The following is a description of a gene set: Human Gene Set: GSE8515_CTRL_VS_IL6_4H_STIM_MAC_DN from publication Jura J, Wegrzyn P, Korostyński M, Guzik K, Oczko-Wojciechowska M, Jarzab M, Kowalska M, Piechota M, Przewłocki R, Koj A (PMID 18498781) Using whole-genome Affymetrix microarrays (HG-U133A), we characterized the transcriptome profile of cultured human macrophages stimulated for 4 h with interleukin 1 (IL-1) or interleukin 6 (IL-6). We found that, in distinction to liver cells, IL-1 is much more potent than IL-6 in modifying macrophage gene expression, although considerable heterogeneity in response of macrophages deriving from individual blood donors was observed. The obtained results permitted to identify a large number of cytokine-responsive genes. coding for proteins of unknown function that are now being studied in our laboratory. They may represent novel targets in the anti-inflammatory therapy. studied in species Homo sapiens Genes down-regulated in comparison of untreated macrophages versus those treated with IL6., and this is the list of marker genes: NTHL1, STK32B, PAX5, IGFALS, EEF2KMT, OPRK1, CCDC134, SBF1, AAMP, ITGB1BP2, MRPS18B, ZNF480, ZFR2, TUBA1C, BRCA1, PLPPR2, PROP1, MAL, CNKSR1, EGLN2, SAMD14 (NCBI Gene Id 201191), IGFBP2, MMS19, POLH, SCNN1A, MCM3AP, FZD8, NRXN2, AKAP6, AASS, BAHCC1, SYMPK, AZGP1, AGPAT4, FAM153A, CORO7, MORC4, SLC6A15, ATXN2L, KCNC1, DNAJA3, C14orf93, GLI1 (NCBI Gene Id 2735), NPC1, ARMCX4, ENTPD2, IHH, RIMS1, CPLX2, LDB2, EDN3, C10orf95-AS1, RBFA, DMTN, WNT4, USH2A, RTL10, NHLH1, UPK3B, LORICRIN, NPTXR, CDH19 (NCBI Gene Id 28513), HS3ST1, SCN2B, IL4R, CA8, OR1E1, ITGB6 (NCBI Gene Id 3694), UTY, POSTN, PTK2, ABCB11, ST3GAL4, LIM2, PAXIP1 (PAX interacting protein 1), FAM169A, TRIM62, MAPRE3, TBX6, MKRN3, MYO9A, PTPRS, HTR1A, CHMP1A, MAGOH2P, CMA1, OR7C1, MGP, KCNG2, GAMT, CAPN15, SMPD3, PLCG1, PNPLA6, METTL3, LDB3, SH2B2, SNAPC2, TNP2, C9, PLOD2, CDK20, SLC7A10, LCN1 (NCBI Gene Id 82904), SLC14A2, CTNNA2, FBXW7, LINC00472, SLURP1, MEIS2, DCAF8, COL9A3, EEF1A2, HOXD9, ATP1B2, VIL1, YKT6 (NCBI Gene Id 63236), IL9, IGLL1, ENPEP, GGT5, ADAMTS12, RBP4, HRH3, ZBTB40, FBXL8, SCMH1, KIT, ZNF157, SYCE1L, HDHD3, PRMT8, F11, RHBDL1, PNRC1, GRPR, SEC14L4, KIR3DX1, ASH1L, MSX2, CPN1 (NCBI Gene Id 1369), CHKB, CACNB1, FAM182B, GABARAPL3, CNPY4 (canopy FGF signaling regulator 4), IGLL3P (NCBI Gene Id 91353), C2orf72, LHX1, KISS1 (KiSS-1 metastasis suppressor), FOXD2, CABP1, CCDC121, CPS1-IT1, B4GALT5, FLT4, SLC6A5, IQSEC2, STMN2, MUC13, GRTP1, B9D2, SSNA1, SNCAIP, CCR3, CA14, ARTN, VRK3, KRT83, SLC6A11, NRIP2, GFI1, FGF5, PAGE1, HNF4G (hepatocyte nuclear factor 4 gamma), RAMP2, TNNI1, MECOM, IL5RA, RAB11B, AJAP1, GNL3LP1, TNIP3, CTSF, MMP15, ALK, ANXA13, CHEK2, GPATCH4, MEX3D, LMAN1L, IGKV3-20 (immunoglobulin kappa variable 3-20), CCR1, LHX5, GTF2H2B